Given this list of marker genes FLI1 (NCBI Gene Id 2313), RPL13A, SLTM, FCER1G, RPN2, HNMT, OPTN, RNF38, TARDBP, MMD, MILR1, TMSB10, TRAM1, CMAS, NKX6-1, RNF139, MAP2K4, DAP3, R3HDM2, PLAAT4, VRK1, DPY19L1, PEX3, MRPL3, NCOR1, DPYD, IARS2, COX7C, ABCC5, ANXA2P2, SQOR, UPF3A, NRDC, SPTBN1, DCAF1, XPO7, CTCF, PLAAT3, ELAC2, RIGI, SFXN3, GGNBP2, PCF11, SMC4, RPL37, GATD3, CHN2, TAC1, STOML2, SUCLG2, KDM7A, EMC2, MEAF6, ZNF395, ING1, PBX1, CASP8AP2, RPS4X, UBE4B, INTS12, GRB10, SMARCC1, SPTLC2, EIF3E, TAF1B, PPIA, POLR1D, MSMO1, XBP1, NSA2, MAP4K4 (mitogen-activated protein kinase kinase kinase kinase 4), NF1, ACOX1, OR2F1, PMM2, PALLD, SAP30L, COPZ1, FAM30A, STK39, RWDD1, HADHB, PSMD1 (proteasome 26S subunit, non-ATPase 1), SRI, PRKACB, RALGAPA1, INTS8, SSX2IP, RPS6 (ribosomal protein S6), CAPRIN1, PEF1, KANSL1L, MRPL35, AVIL, NIPSNAP1 (NCBI Gene Id 8508), ZNF706, SLC4A2, STK38, GSE1, WDR11, CLSTN1, COX11, RPL13, CTNNA1, AGPAT5, EPAS1, RPS16, JAK1, CD1C (NCBI Gene Id 911, CD1c molecule), LCMT1, TESPA1, PIBF1, CZIB (CXXC motif containing zinc binding protein), GIMAP6, PEX1, AAMDC, ADD3, VAV2, PRKCQ, ZNF22, RPL36, UNC45A, HPGD, CANX, APIP, PJA1, ENOPH1 (enolase-phosphatase 1), ATP5ME, DTWD1, SRP54, TRPC4, FBLN5, COPS6, PDE6G, SEMA4C, METTL3 (NCBI Gene Id 95719), FTO, FUT8, PDGFC (NCBI Gene Id 56034), LTA4H, TASOR, RRS1, ZMYND8, RPL26, RPS27L, RPL34, SMYD3, KIDINS220, COX6C, GBA1LP, MRPL34, ILRUN, APOBEC3A, NAA38, PKD2, DNAJC10, MTARC1, ERG28, PRDX1, ERI2 (ERI1 exoribonuclease family member 2), ALG6, AKR1C3 (NCBI Gene Id 96424), HOXB8, TPST1, COX6B1, KLRD1, FKBP3, CD3G, LAT2, CEP63, VPS13B (NCBI Gene Id 54990), SGPP1, CENPU (NCBI Gene Id 79682), CRTC3, SYCP2, CNPY2, TUBB4B, APOL1, SKAP1, MIA, IK, CBFB (core-binding factor subunit beta), TARP, CASK, SEMA3C (semaphorin 3C), PIKFYVE, EIF3D, NDRG1, TREM2, EXT1, ZFYVE16, UQCC1, HCP5, EFNA3, ESYT1, PPP2R5A, GNL3LP1, DPAGT1, TRIP4, here is a description of the gene set: Human Gene Set: GSE3982_EOSINOPHIL_VS_BASOPHIL_DN studied in species Homo sapiens In the present study we used Affymetrix oligonucleotide microarrays to produce gene transcription profiles for the major leukocyte types in humans. This comprehensive dataset enabled us to not only establish which genes were expressed in each leukocyte type, but also which genes were expressed in each subset after activation. The used of a comprehensive dataset of gene profiles from all the major human leukocyte subsets enabled a novel and powerful means for identification of genes associated with single leukocyte subsets, or different immune paradigms. from publication Jeffrey KL, Brummer T, Rolph MS, Liu SM, Callejas NA, Grumont RJ, Gillieron C, Mackay F, Grey S, Camps M, Rommel C, Gerondakis SD, Mackay CR (PMID 16474395) Genes down-regulated in comparison of eosinophils versus basophils.